The following is a description of a gene set: species: Homo sapiens Human Gene Set: WP_HEART_DEVELOPMENT Heart development, and this is the list of marker genes: FGF10 (NCBI Gene Id 2255), FOXC2, SMYD1, TBX2, NFATC2, BMP4, MIR145, MIR143, ISL1, HAND2, NFATC1, FOXC1, TBX5, NFATC4, MIR1-1, VEGFC, GATA4 (GATA binding protein 4), BMP10, BMPR2, SHH, ERBB3, HAND1, SMAD1, VEGFA, TBX20, BMP2, GATA6, FOXH1, SRF, FOXA2, TBX1, IRX4, CTNNB1, PTPN11, NKX2-5, BMPR1A, NFATC3, PITX2, HEY2, BHLHE40, FGF8, VEGFB, HEY1, NOTCH1, SMAD4, MAPK1, MEF2C